The following is a description of a gene set: A process in which force is generated within smooth muscle tissue, resulting in a change in muscle geometry. This process occurs in the gastro-intestinal system. Force generation involves a chemo-mechanical energy conversion step that is carried out by the actin/myosin complex activity, which generates force through ATP hydrolysis. The gastro-intestinal system generally refers to the digestive structures stretching from the mouth to anus, but does not include the accessory glandular organs (liver, pancreas and biliary tract). species: Mus musculus Mouse Gene Set: GOBP_GASTRO_INTESTINAL_SYSTEM_SMOOTH_MUSCLE_CONTRACTION, and this is the list of marker genes: Htr1d, Nmu, Sulf2, Sulf1, Ptger4, Kcnma1, Ghsr, Tacr2, Ghrl, Scn11a, Ptger3, Spx, Kit (NCBI Gene Id 16590), Htr2b (NCBI Gene Id 98641), Ptafr